The following is a description of a gene set: studied in species Mus musculus Enables the transfer of amino acids from one side of a membrane to the other. Amino acids are organic molecules that contain an amino group and a carboxyl group. Mouse Gene Set: GOMF_AMINO_ACID_TRANSMEMBRANE_TRANSPORTER_ACTIVITY, and this is the list of marker genes: Slc38a9, Slc6a11, Slc25a38, Slc47a1, Slc38a4 (NCBI Gene Id 76312), Slc25a2, Tmem44, Slc1a4, Grin3b, Slc7a3, Ctns, Grik5, Slc3a2, Slc6a6, Slc43a2, Slc7a5, Slc47a2, Slc7a4, Slc1a3, AU018091, Gria2, Grik4, Slc1a6, Ucp2, Slc7a12, Gria1, Slc1a5, Slc16a2, Grin3a, Slc16a10 (NCBI Gene Id 72472), Slc1a7, Slc6a8, Slc6a20a, Slc6a7, Slc25a12, Slc6a18, Sfxn1, Gria3, Slc22a4, Slc6a19, Slc38a3, Grik2, Nat3, Slc36a2, Slc7a2, Slc36a3, Slc17a8, Tspo2, Slc36a4, Slc38a10, Slc25a18, Slc7a13, Pdpn, Slc17a7, Slc38a5, Grin2d (glutamate receptor, ionotropic, NMDA2D (epsilon 4)), Slc1a2, Slc6a9, Grid2, Slc25a15, Nherf1, Slc38a6, Slc1a1, Slc6a20b, Slc38a11, Slc7a1, Grin2c, Slc7a8, Slc6a14 (solute carrier family 6 (neurotransmitter transporter), member 14), Grid1, Grin2b, Slc6a15, Slc6a12, Slc25a29, Slc7a9, Slc7a7, Slc25a13, Mfsd12, Slc36a1, Slc25a26 (NCBI Gene Id 71253), Slc66a1 (solute carrier family 66 member 1), Slc22a2, Grik3, Slc6a1, Slc43a1, Slc17a6, Slc7a10, Slc38a2, Grin2a, Slc15a4, Gria4, Slc6a5, Slc38a7, Slc38a8, Slc32a1 (solute carrier family 32 (GABA vesicular transporter), member 1), Slc7a6, Grin1, Slc38a1, Slc13a3, Slc25a22, Slc6a13, Slc7a14, Slc7a15, Sfxn3, Slc7a11, Grik1